Given this list of marker genes PSMD13, DLL1, NOTCH1, PSMA3 (NCBI Gene Id 5684), PSMA4, PSMD6, PSMC1, RIPPLY2, PSMD8, BMP4, PSMC6, MESP2, PSMB2, ADRM1 (NCBI Gene Id 11047), PSMD14, PSMB4, DLL3, WNT3A, PSMA2, PSMD12, KAT2B, PSMA7, PSMC3, CREBBP (CREB binding protein), MAML3, HES7, PSMC4 (proteasome 26S subunit, ATPase 4), NOG, TBX6 (T-box transcription factor 6), PSMB1, PSMA1, LFNG, PSMD11 (proteasome 26S subunit, non-ATPase 11), PSMD1, PSMD7, PSMB5, TBXT, CTNNB1 (NCBI Gene Id 1499), MSGN1, FGFR1, PSMD2, PSMD3, KAT2A, MAMLD1, SNW1, MAML2, PSMA5, SEM1, EPHA4, PSMB3, RBPJ, PSMB6, PSMB7, PSMA6, MAML1, PSMC5, PSMC2, EP300, LEF1, here is a description of the gene set: studied in species Homo sapiens Human Gene Set: REACTOME_FORMATION_OF_PARAXIAL_MESODERM Formation of paraxial mesoderm